Given this list of marker genes CFH, COG1, PRDX1, CD46, ADAMTS13, DGKE, TMEM165, CFHR3, C1GALT1C1, CFHR1, MTRR, CFB, ZNFX1, THBD, CFI, C3, MMACHC, here is a description of the gene set: A thrombotic microangiopathy with presence of non-immune, intravascular hemolytic anemia, thrombocytopenia and acute kidney injury. A vicious cycle of complement activation, endothelial cell damage, platelet activation, and thrombosis is the hallmark of the disease. Hemolytic-uremic syndrome species: Homo sapiens Human Gene Set: HP_HEMOLYTIC_UREMIC_SYNDROME